Given this list of marker genes Ep400, Ppp2ca, Klrc2, Plg, Hnrnpm, Itga4, Sirpa, Ep300, Klrd1, Ppp2r1a, Lck, here is a description of the gene set: Binding to a protein antigen. species: Mus musculus Mouse Gene Set: GOMF_PROTEIN_ANTIGEN_BINDING